The following is a description of a gene set: The directed movement of an endothelial cell guided by a specific chemical concentration gradient. Movement may be towards a higher concentration (positive chemotaxis) or towards a lower concentration (negative chemotaxis). Human Gene Set: GOBP_ENDOTHELIAL_CELL_CHEMOTAXIS species: Homo sapiens, and this is the list of marker genes: FGFR1, MET (NCBI Gene Id 4233), VEGFA, NRP1, HRG, HSPB1, PRKD2, CCN3, FGF4, CXCL13, MIR424, FGF16, TMSB4X, KDR, SEMA5A, NR4A1 (nuclear receptor subfamily 4 group A member 1), NOTCH1, FGF2, PRKD1, HMGB1, MIR149, THBS1, EGR3, LGMN, RAB13, SMOC2, MIR16-1, PLEKHG5, GAB1, FGF18, CORO1B, P2RX4, FGF1